Given this list of marker genes RIN2, ALCAM, ADH5, TADA3, KCNAB2, HMGA1, EREG, ST3GAL6, TACSTD2, SERPINE1, ENG, CHST2, OAZ2, COG2, ARL4C, NCAPD3, GRB2, ZNF266 (NCBI Gene Id 10781), CCDC93, PSD4, SYNJ1, MYO1F, DNASE2, KANK1, TPR, CTCF, TXN2, ZNF3, RGS2, CAMKK2, GNA12, STK10 (serine/threonine kinase 10), LYL1, AP2M1, RPA1, GGA2, SFXN3 (sideroflexin 3), LHFPL2, FAF2, MARCKSL1, MPP1, IARS1, ANKRD28, HIPK2 (homeodomain interacting protein kinase 2), HCP5, RXRB, ADAM8, BCAR3, IL18, MLX, LBP, EIF2S3, RPGR, BID, FBXL14, TNIP1, ATM, GTF2H1, ZNF710, SLC3A2, RBM38, DCAF11, IGBP1, HNRNPA3, THBD, ZCCHC24, PLIN2, BAIAP2, ENC1, RXRA (NCBI Gene Id 6256), FOXO1, SLC23A2, NDRG1, GNPDA1, CCR2, SRP72, ARHGAP22, PDHX, GBA1, CDC42EP3, ABR, ADA, GAS2L1, SETD3, TRIM66, GOLGA2, MAPK14, NEK4, MEF2D, MINK1, GEMIN2, IL27RA, GPX4, PHF21A, OLR1, FAM53B (NCBI Gene Id 9679), HHEX, GRAMD4, LY6G6C, ALMS1, MAP3K14, PDE3B, MRFAP1L1, MARS1, GGA3, TCTA, ASMTL, PSTPIP1, LMNA, NISCH, TMEM41B, MAN2A2, CTSH, ZFP36L2, XYLT1, SIKE1, EEF1E1, TUBGCP2, HOMER3, PPP2R5C, KLHDC3, TNFRSF11A, SLC7A7, CBLB, RRS1, AKAP1, ACAA2, GSTO1 (NCBI Gene Id 9446), MYCBP, MYO10, KCNQ1, ATRN, NUMA1, PIK3CG, PEX1, DNTTIP2, LAIR1, TMEM243, FYN, ST8SIA4, SLC25A14, LPCAT1, SERTAD2, ITGB5, PHLDA1 (pleckstrin homology like domain family A member 1), ACP5, POLR2J, STK38L, AMPD3, DUSP14, NR1H3, POLR2H, LTA4H, AHNAK, SLF2, C1orf216, ATP5PO, AGGF1, OGA, CRIP1, PLXNB2, ADORA3, PLCB3, ZBTB7A, SEC24C, ARHGEF2, IQGAP2, POLR2A, CSK, ATP6V0A1, TGFBR2, GZMA, PIK3CB, LPL, ACP2, UBE2I, USP22, GNA15, PFDN4, PLEC, HPCAL1, PRKD2, SASH3, SLC16A3, WIPI2, SLC11A1, LIG1, VPS39, DNAJC11, MAEA, HDAC5, RAB9A, FMNL1, TRAM2, SMC4, NDUFV1, UBAC1, CDK9, NCOR2, here is a description of the gene set: Human Gene Set: GSE22140_HEALTHY_VS_ARTHRITIC_MOUSE_CD4_TCELL_DN A general defect of GF K/BxN T cell proliferation response toward antigen motivated us to look for the impairment in GF K/BxN T cells that might leads to the low Ab production and reduced disease phenotype seen in GF K/BxN mice. To find the difference between GF and SPF K/BxN T cells in a broad and non-biased fashion, we performed gene-expression profiling of these cells using microarrays. studied in species Homo sapiens Genes down-regulated in CD4 T cells under specific pathogen free conditions: healthy versus arthritis (KRN model). from publication Wu HJ, Ivanov II, Darce J, Hattori K, Shima T, Umesaki Y, Littman DR, Benoist C, Mathis D (PMID 20620945)